The following is a description of a gene set: species: Homo sapiens Any process that stops, prevents, or reduces the frequency, rate, or extent of a humoral immune response mediated by circulating immunoglobulin. Human Gene Set: GOBP_NEGATIVE_REGULATION_OF_HUMORAL_IMMUNE_RESPONSE_MEDIATED_BY_CIRCULATING_IMMUNOGLOBULIN, and this is the list of marker genes: FOXJ1, PTPN6, FCGR2B, CR1, C4BPB, C4BPA, CR2, SUSD4, CR1L, CD46